The following is a description of a gene set: from publication Chen Y, Wang X (PMID 31504780) Mouse Gene Set: MIR_673_5P Genes predicted to be targets of miRBase v22 microRNA mmu_miR_673_5p in miRDB v6.0 with MirTarget v4 prediction scores > 80 (high confidence targets). studied in species Mus musculus, and this is the list of marker genes: Bltp3a, Dcun1d4, Btg2, Smad5, Gpd2, Zbtb34 (zinc finger and BTB domain containing 34), Slc25a25, Slc35f4, Chmp3, Ttyh3, Fndc3a, Csnk1d, Limk2, Tfcp2l1, Tead1, Tma7, Ap1g1, Arl6ip1, Cnot1, Pvalb, Mmd, Chst2, Nqo2, Msn, Rab14, Samd4, Slc39a6, Ccnyl1, Id4, Yipf5, Gimap6, Atad2b, Zbtb33, Rps6kb1, Grm5, Tia1, Plekhj1, Ppif, Dio1, Rbm12, Slc35f1, Epha7 (NCBI Gene Id 13841), Camk2a, Cenpw, Rnf111, Tab3, Usp45, Braf, Arih2, Homer1, Brpf3, Lpin1, Fbxo46, Vav2, Usp25, Fzd4, Ror1, Slitrk6 (SLIT and NTRK-like family, member 6), Tcf7l2, Rnf7, Chn2, Akirin1, Pdia5, Tmem199, Pparg, Mtmr4, Gbp3, Tmem170b, Gcc2, Ube2n, Unc5d, Larp4, Stradb, Rpn2, Hephl1, Tox, Lin7a, Pianp, Stx8, Ippk, Ctr9, Sox8, Nras, Gramd1c, Necap1, Stx5a, Kif3a, Odf2, Sv2a, Klf17, Dnaja1, Tmem161a, Miga2, Zbtb18, Edrf1, C2cd5, Frmd6, Dmxl2, Nipal4, Gata3, Xpo1, Cds1, Zfp850, Zhx1, Pkn2, Dzip1l, Trim37, Sema4c, F8, Sox11, Gata2 (NCBI Gene Id 14461), Srp19, Csnk1g1, Mrps14, Vdac3, Sema3b, Mmp16, Hsdl1, Ing5, Map1b, Plk2, Sv2b, Usp9x, Clec4e, Asph (aspartate-beta-hydroxylase), Naa15, Pdzk1ip1, Mideas, Bcl10, Dusp2, Slc5a1, Sult1a1 (NCBI Gene Id 20887), Nup58, Kif21b, Ncapg, Gns, Ammecr1l, Lonrf1, Gse1, Raph1, Eya1, Dpf1, Spesp1, Txn2, Cyp2c50, Apaf1, Vgf, Btg1, Ufsp2, Tmem59, Klhdc3, Wnk2, Ino80d, Rap2b, Kat2b, Chic1 (NCBI Gene Id 331484), Chka, Syn2, Runx1 (NCBI Gene Id 12394), Calm3, Septin6, Rbfox1, Prr14l, Septin11, Kras, Appbp2, Gzf1, Cpeb3, Prl2a1, Amotl2, Zbtb10, Cav1, Sp6, Il6ra, Insm2, Nlk, Cdyl, Gxylt1, Cyp2c54, Arfgef1, Hmgn1, Rgs8 (NCBI Gene Id 67792), Fbxo34, Cd99l2, Dmrt3, Dusp18, Adamtsl3, B3gnt7, Plcl2, E2f7, Tardbp, Klf8, Ppm1k, Lctl, Cnr1, St6galnac3, Mme, Marchf6, Galnt1, Ap1s3, Rpgrip1l, Celf1, Acly, Zfp106, Eri3, AI593442, Maip1, Trappc8, Mlxip, Myh9, Dipk1a, Glra2, Rassf3, Dnajc13 (NCBI Gene Id 546159), Clk2 (NCBI Gene Id 99827), Dtx4, Acer2, Ikzf1, Mknk2, Atp5mc3, Slitrk1, Strbp, Midn, Tmem178b, Nr5a2, Nhlh2, Npas3, Chd7, Osbpl11, Trim66, Hdx, Zmym4 (NCBI Gene Id 67785), Arl4c, Cdh11, Kbtbd8, Dcaf12, Edil3, AU040320, Pex19, Hipk3, Nedd1, Rreb1, Pdha1, En2 (NCBI Gene Id 13799), Kpnb1, Rmnd5a, Eef1b2, Pip5kl1, Patz1, Creb1, Frmpd3 (FERM and PDZ domain containing 3), Atp13a3, Plppr4, Coa5, Apc, L2hgdh, Kctd8, Sv2c, Sall2, Ampd3, Cald1, Ptbp2, Fbxw7, Kmt5b, Insyn2a, Slc25a53, Tnrc6b, C2cd2, Ugcg, Zfp36, Pclo, Dyrk1a (NCBI Gene Id 76465), Fam98a, Cds2 (CDP-diacylglycerol synthase 2), Slc35a3, Hoga1, Bcor, Adamts6, Zfp217, Ncald, Syt14, Bltp1, Fam168b, Slc7a11, Serf2, Usp46, Tsc22d2, Afap1, Itsn2, Cdk5r1, Zeb2, Dnajc5b, Abhd17c (abhydrolase domain containing 17C), Pds5b, Map3k2, Adrb2, Spata13, Shroom2, Colgalt2, Dpyd, Trim6